The following is a description of a gene set: studied in species Mus musculus from publication Motenko H, Neuhauser SB, O'Keefe M, Richardson JE (PMID 26092688) Mouse genes annotated to increased chronic myelocytic leukemia incidence (MP:0005481) retrieved from the Mouse Genome Informatics database via MouseMine Mouse Gene Set: MP_INCREASED_CHRONIC_MYELOCYTIC_LEUKEMIA_INCIDENCE, and this is the list of marker genes: Tet2, Kit, Rigi, Irf8, Esr2, Sipa1, Kdm6a, Chordc1, Zfand2b, Alox15, Junb, Jak2